The following is a description of a gene set: Genes positively differentially expressed in cell type: NK cell upon treatment with cytokine: IL-17E in mouse lymph nodes in vivo. Mouse Gene Set: CUI_NK_CELL_IL17E_RESPONSE_UP species: Mus musculus from publication Cui A, Huang T, Li S, Ma A, Pérez JL, Sander C, Keskin DB, Wu CJ, Fraenkel E, Hacohen N (PMID 38057668) Cytokines mediate cell-cell communication in the immune system and represent important therapeutic targets. A myriad of studies have highlighted their central role in immune function, yet we lack a global view of the cellular responses of each immune cell type to each cytokine. To address this gap, the authors created the Immune Dictionary, a compendium of single-cell transcriptomic profiles of more than 17 immune cell types in response to each of 86 cytokines (>1,400 cytokine-cell type combinations) in mouse lymph nodes in vivo. A cytokine-centric view of the dictionary revealed that most cytokines induce highly cell-type-specific responses. For example, the inflammatory cytokine interleukin-1β induces distinct gene programmes in almost every cell type. A cell-type-centric view of the dictionary identified more than 66 cytokine-driven cellular polarization states across immune cell types, including previously uncharacterized states such as an interleukin-18-induced polyfunctional natural killer cell state., and this is the list of marker genes: Trnau1ap, Pno1, Taldo1, L3mbtl2, Pomp, Dhps, Tmem35b, Erh, Ppm1g, Sfxn1, Hnrnpm, Uqcr11, Raly, Bin3, Ppig, Mrto4, Tubb4b, Naip5, Pfn1 (NCBI Gene Id 18643), Pa2g4, Elk3 (ELK3, member of ETS oncogene family), Rsu1, Fam162a, Fam174a, Agpat5, Txndc9, Tmem80, Klrg1 (killer cell lectin-like receptor subfamily G, member 1), Ubqln2, Myo6, Rpf2